Given this list of marker genes Sox10, Enpp1, Cntnap2, Ckap5, Plp1, Tenm4, Ulk4, Cntn2, Clu, Mobp, Ccdc39, Omg, B4galt5 (NCBI Gene Id 99384), Ncstn, Fa2h, Tlr2, Cntnap1, Mal, Kcnj10, Cntn1, 9630013A20Rik, Gpm6b, B4galt6, Nkx6-2, Abca2, Ercc2, Id4, Aspa, Mios, Pten (NCBI Gene Id 70161), Myrf, Hes5, Fgfr3, Mag, here is a description of the gene set: Mouse Gene Set: GOBP_AXON_ENSHEATHMENT_IN_CENTRAL_NERVOUS_SYSTEM The process in which a glial cell membrane closes around an axon in the central nervous system. This can be a myelinating or a non-myelinating neuron-glial interaction. species: Mus musculus